Given this list of marker genes nef, PPIA, vpr, VPS37D, UBC, VPS37C, MVB12A, VPS37B, gag-pol, VPS28, FURIN (furin, paired basic amino acid cleaving enzyme), MVB12B, TSG101, vpu, UBAP1, rev, UBB, NMT2, vif, UBA52, RPS27A, VPS37A, gag, env, here is a description of the gene set: part of: Late Phase of HIV Life Cycle studied in species Homo sapiens Virion assembly packages all the components required for infectivity. These steps include two copies of the positive sense genomic viral RNA, cellular tRNALys, the viral envelope (Env) protein, the Gag polyprotein, and the three viral enzymes: protease (PR), reverse transcriptase (RT), and integrase (IN). The viral enzymes are packaged as domains within the Gag-Pro-Pol polyprotein. Reactome Pathway: Assembly Of The HIV Virion